The following is a description of a gene set: Catalysis of the transfer of a methyl group to the carbon atom of an acceptor molecule. species: Mus musculus Mouse Gene Set: GOMF_C_METHYLTRANSFERASE_ACTIVITY, and this is the list of marker genes: Coq5, Nsun5, Trmt2b, Trmt2a, Nop2, Nsun4